Given this list of marker genes CDC25A, RBBP4, CENPF, FOXM1, LIN54, PLK1, PKMYT1, MYBL2, LIN37, LIN52, CCNB1, WEE1, CDC25C, CCNB2, EP300, LIN9, here is a description of the gene set: part of: G2/M Transition species: Homo sapiens At mitotic entry, Plk1 phosphorylates and activates Cdc25C phosphatase, whereas it phosphorylates and down-regulates Wee1A. Plk1 also phosphorylates and inhibits Myt1 activity. Cyclin B1-bound Cdc2, which is the target of Cdc25C, Wee1A, and Myt1, functions in a feedback loop and phosphorylates the latter components (Cdc25C, Wee1A, Myt1). The Cdc2- dependent phosphorylation provides docking sites for the polo-box domain of Plk1, thus promoting the Plk1-dependent regulation of these components and, as a result, activation of Cdc2-Cyclin B1.<p>PLK1 phosphorylates and activates the transcription factor FOXM1 which stimulates the expression of a number of genes needed for G2/M transition, including PLK1, thereby creating a positive feedback loop. Reactome Pathway: Polo-like kinase mediated events